The following is a description of a gene set: Human Gene Set: GAVISH_3CA_METAPROGRAM_B_CELLS_HSP_STRESS In this study, an extensive analysis was conducted to define meta-programs (MPs) capturing intra-tumor heterogeneity across a spectrum of tumor types. The approach utilized non-negative matrix factorization (NMF) to analyze each cell type separately within individual tumor samples. This involved the analysis of malignant cells, macrophages, fibroblasts, endothelial cells, epithelial cells, T-cells, and B-cells. NMF was executed with varying parameter values (K=4, 5, 6, 7, 8, 9), thereby generating 39 programs for each cell type per sample. Each NMF program was summarized by the top genes based on NMF coefficients.\nRobust MPs were then delineated for each cell type using a set of stringent criteria, including recurrence within the same tumor, similarity to programs in other tumors, and non-redundancy within a tumor. Subsequently, these robust NMF programs were clustered (per cell type) based on Jaccard similarity, leading to the identification of MPs associated with each cell type.\nTo enhance the quality of the MPs, a refinement steps were undertaken, involving the removal of MPs suspected of reflecting low-quality data (with an overrepresentation of ribosomal proteins or mitochondrial-encoded genes), single-study inclusion, or similarity to miss-annotated cell types. species: Homo sapiens Genes upregulated in subsets of cells of a given type within various tumors from publication Gavish A, Tyler M, Greenwald AC, Hoefflin R, Simkin D, Tschernichovsky R, Galili Darnell N, Somech E, Barbolin C, Antman T, Kovarsky D, Barrett T, Gonzalez Castro LN, Halder D, Chanoch-Myers R, Laffy J, Mints M, Wider A, Tal R, Spitzer A, Hara T, Raitses-Gurevich M, Stossel C, Golan T, Tirosh A, Suvà ML, Puram SV, Tirosh I (PMID 37258682), and this is the list of marker genes: IER2, CD83, HSP90AB1, CHORDC1, STIP1, BCL2A1, UBC, AHSA1, HSPE1, CD69, CCL4, HSPB1, UBB, HSPA1B, KLF6, CCR7, SLBP, DNAJB4, HSPA6, NFKBIA, MRPL18, DNAJB1, PMAIP1, NUDC, HSPA8, FOS, TAF7 (NCBI Gene Id 93080), SMIM14, HSP90AA1, IGHG1, NFKBID (NCBI Gene Id 84807), EGR1, CACYBP, DNAJA1, DEDD2, SLC5A3, ZFAND2A, MIR155HG, HSPH1, EGR3, JUN, NR4A1, FKBP4, IGHA1, DUSP2, MYC, DDX5, HSPA1A, ANKRD12, HSPD1